The following is a description of a gene set: Loci bound exclusively by SIN3A in myotubules. species: Mus musculus The highly related mammalian Sin3A and Sin3B proteins provide a versatile platform for chromatin-modifying activities. Sin3-containing complexes play a role in gene repression through deacetylation of nucleosomes. Here, we explore a role for Sin3 in myogenesis by examining the phenotypes resulting from acute somatic deletion of both isoforms in vivo and from primary myotubes in vitro. Myotubes ablated for Sin3A alone, but not Sin3B, displayed gross defects in sarcomere structure that were considerably enhanced upon simultaneous ablation of both isoforms. Massively parallel sequencing of Sin3A- and Sin3B-bound genomic loci revealed a subset of target genes directly involved in sarcomere function that are positively regulated by Sin3A and Sin3B proteins. Both proteins were coordinately recruited to a substantial number of genes. Interestingly, depletion of Sin3B led to compensatory increases in Sin3A recruitment at certain target loci, but Sin3B was never found to compensate for Sin3A loss. Thus, our analyses describe a novel transcriptional role for Sin3A and Sin3B proteins associated with maintenance of differentiated muscle cells. Mouse Gene Set: VANOEVELEN_MYOGENESIS_SIN3A_TARGETS from publication van Oevelen C, Bowman C, Pellegrino J, Asp P, Cheng J, Parisi F, Micsinai M, Kluger Y, Chu A, Blais A, David G, Dynlacht BD (PMID 20956564), and this is the list of marker genes: Gnl2, Suclg2, Coa7, Pkp4, Gemin5 (gem nuclear organelle associated protein 5), Rnf114, Ptdss2, Cks1b, Bcl2l11, Gns, Txnrd1, Ptpn1, Scamp2, Mrps33, Rad51ap1, Mrps36, Supt6, Prrg4, Mxi1 (NCBI Gene Id 17859), Rcn1, Rnf13, Bbs5, Terf2ip, Pmm2, Cdh6, Mbtd1, Surf2, 4833439L19Rik, Gpc5, Lpcat3, Tfb1m, Cep85, Tjp1, Cab39l, Sdc1, Tab3, Btd, Atp6v1a, Clcn3, Sclt1, Dctd, Pop7, 2310039H08Rik, Med15, Abhd6, Nap1l4, Phf5a, Sipa1l1, Coq10b, Tbca, Zfp84, Slc25a40, Urb2, Iqcb1, Sorcs2, Rpp38, Ppp2r2a, Cct5, Trpv2, Gng5, Uchl3, Prxl2c, Parpbp, Mctp2, Usp5, Gpank1 (NCBI Gene Id 81845), Sh3gl1, Ric8a, Zdhhc20, Appl2, Polr1g, Zcchc24, Eda2r, Vps35, St6gal1 (beta galactoside alpha 2,6 sialyltransferase 1), Fam114a2, Zfp667, Tac4, Ankrd26, Nppb, Camk2a, Actr1b, Sstr1, Lin28a, Ing5, Ahcy, Mrpl57, Zwilch, Arpc1b, 2810004N23Rik, Coa5, Ergic3, Btbd6, Chchd4, Stk19, Pacc1, Dpagt1, Arhgap33, Baz1a, Cnppd1, Fam53b, Gtpbp2, Serf1, Cmas, Mink1, Ogfod2, Nmd3, Arhgap5, Mzt1, Blzf1, Ciart, Mlycd, Rps9, Zfp248, Hoxc8, Vsir, Vps52, Lif (leukemia inhibitory factor), Ldlr, Ankrd13b, Pnpla6, Lrig1, Ctu2, Mtnap1, Vamp4, Pik3ip1, Ergic1, Hax1, Flii (NCBI Gene Id 74028), Ftl1, Tbc1d24, Ppp2r3c, N6amt1, Trmt6, Gon7, Slc39a3, Enoph1, Dclre1b, Vamp3, Pbld2, Clcn5, Wwp2, Myo6, Tmco3, Mtrf1l, Cep68, Abcc5, Idh3a, Ppp1r11, Ccdc71, Slc7a6os, Nrm, Mfsd5, E2f6, Rnf181, Slc35a5, Dap3, Dtl, Kank2, Zfp189, Lmln, Vmp1 (vacuole membrane protein 1), Erf, Ppp3cb, Ola1, Mrps16 (mitochondrial ribosomal protein S16), Zbtb5, Hs2st1, Thoc3, Pgls, Pibf1, Dusp10 (NCBI Gene Id 98270), Fbxl8, Hmga1, Hsp90b1, Arhgap22, Rpsa, Ndrg1, Nop16, Pfkl, Ndor1, Colgalt1, Kif17, Asxl1 (ASXL transcriptional regulator 1), Noa1, Anxa5, Rara, Hacd3, Hipk2, Msantd4, Phkb, Rhbdd2, Slc12a9, Tomm34, Nsun3 (NCBI Gene Id 77121), Chtf8, Ogn, Tsen54, Dusp7, Ripor1, Rala, Dpp3, Sod2, Pms2, Abi2, Eif2b1, Dusp2, Hmox1, Creb1, Rae1, Fhit, Rps24, Gfer, Gnptab, Hp1bp3, Nln, Parg, Etfb, Ddx51, Nfil3, Riox2